The following is a description of a gene set: from publication Chen Y, Wang X (PMID 31504780) species: Homo sapiens Human Gene Set: MIR6890_3P Genes predicted to be targets of miRBase v22 microRNA hsa-miR-6890-3p in miRDB v6.0 with MirTarget v4 prediction scores > 80 (high confidence targets)., and this is the list of marker genes: C4BPA, ZMYM4, KAT14, PLA2G15, RAP2C, NXPH2, MEOX2, HEPH, ZNF710, UNC119B, CLN5, DOCK4, POU2F1, DDX43, INA, USH2A, PRMT2, XPO7, CAB39, SFXN5, PPP4R4, ABHD14B, INTS6L, REEP3, SEC63, IL6ST, KCNC2, SLC25A25, UBE2W, LHFPL4, TWF1, SNCA, RBIS, SFPQ, DNAJB9, DAG1, RHAG, ALDH1A2, CGGBP1, ATXN1L, LARGE1, HSF2, TEX30, PEG10, UNC5B, DISC1, DFFA, CALM1, TSPAN33, SBNO1, CEP55, ORAI2, CAND2, SAMD5 (sterile alpha motif domain containing 5), PRR14L, PGAM4, FOXN3, SOS2 (SOS Ras/Rho guanine nucleotide exchange factor 2), RGL2, FXR1, GANC, GUCY1A2, WAC, PHF12, COG6, CCDC81, PLEKHG4, ZNF512, BROX, TRAF6, PROCR, PERP, DPH5, MFNG, RFX3, PGAM1, WDR43, SPPL3, BPNT2, NELL2 (neural EGFL like 2), C9orf152, BOD1, PAQR9, ITM2B, TMEM104 (NCBI Gene Id 54868), ADAMTS4, ADAM18, APLN, DESI2, JCAD, UBN1, OTUB2